Given this list of marker genes GNA11, ATP1A3, GNAQ, TMEM53, PEX10, OSTM1, MYH11, ATP1A2, CYSLTR2, SF3B1, MYL9 (myosin light chain 9), BAP1, SLC1A3, CACNA1A (NCBI Gene Id 773), ACTA2, LOXL1, here is a description of the gene set: Abnormal dilatation of the iris. species: Homo sapiens Human Gene Set: HP_MYDRIASIS Mydriasis